Given this list of marker genes Ttn, Eln, Mfap5, Emilin1, Efemp2, Fbln5, Emilin2, here is a description of the gene set: Mouse Gene Set: GOMF_STRUCTURAL_MOLECULE_ACTIVITY_CONFERRING_ELASTICITY species: Mus musculus The action of a molecule that contributes to the structural integrity of a complex or assembly within or outside a cell, providing elasticity and recoiling.